Given this list of marker genes Atat1, Gtf3c4, Pygo2, Nat9, Gtf2b, Aanat (NCBI Gene Id 11298), Kat8, Kat6a, Naa60, Acaa1a, Abhd14b, Hadhb, Ncoa3, Naa15, Kat6b, Nat8l, Serinc5, Acat3, Naa80, Gnpnat1, Pdcd5-ps, Bloc1s1, Nat8f1, Kat7 (NCBI Gene Id 217127), Hat1, Mcm3ap, Lpcat4, Brpf3, Taf10, Lpcat2, Ncoa1, Nat10, Sphk1, Ogt, Chat, Mogat2, Serinc1, Sat1, Acaa1b, Ep300, Pdcd5, Nat2, Pafah1b2, Acat2, Cdyl, Jade1, Dbt, Oga, Atf2, Msx3, Sat2 (NCBI Gene Id 69215), Acat1, Kat5, Gcat (glycine C-acetyltransferase (2-amino-3-ketobutyrate-coenzyme A ligase)), Nat8f3, Naa20, Tmem68, Nat8f2, Naa10, Hgsnat, Nat8f4, Nat8f5, Kat2b, Ifnb1, Nat8b-ps (N-acetyltransferase 8B, pseudogene), Meaf6, Bcas3, Fcor, Elp3, Nat1, Naa25, Clock, Naa11, Brd1, Naa40, Lpcat1, Gnpat (glyceronephosphate O-acyltransferase), Ing3, Pafah2, Kat2a, Phf10, Pafah1b3, Nat8, Satl1, Tada2a, Esco2, Acaa2, Ing4, Casd1, Smarce1, Nat8f6, Fasn, Naa50, Taf9, Kat14, Nags, Jade2, Mettl8, Dlat, Taf1, Crat, Brca2, Naa12, Naa16, Esco1, Naa30, Nat8f7, Nupr1, Lcat, Nat3, Usp22, Nat14, Med24, Nap1l2, Brpf1, Crebbp, here is a description of the gene set: species: Mus musculus Catalysis of the transfer of an acetyl group to an acceptor molecule. Mouse Gene Set: GOMF_ACETYLTRANSFERASE_ACTIVITY